Given this list of marker genes AGPAT2, KCNQ1OT1, BSCL2, CDKN1C, IGF2, PPARG, CAV1, KCNQ1, CAVIN1, INSR, FOS, here is a description of the gene set: Human Gene Set: HP_OVERGROWTH_OF_EXTERNAL_GENITALIA Overgrowth of external genitalia studied in species Homo sapiens